The following is a description of a gene set: Mouse Gene Set: GOMF_VOLTAGE_GATED_CALCIUM_CHANNEL_ACTIVITY_INVOLVED_IN_REGULATION_OF_CYTOSOLIC_CALCIUM_LEVELS species: Mus musculus Regulation of cytosolic calcium ion concentrations via the directed movement of calcium ions across the plasma-membrane into the cytosol via the action of a voltage-gated calcium ion channel., and this is the list of marker genes: Rimbp2, Cacna1a, Htr1b, Tspoap1, Cacnb2, Cacnb4, Cacna1d, Cacna1e, Cacna1b